The following is a description of a gene set: studied in species Homo sapiens Human Gene Set: WP_NANOPARTICLE_TRIGGERED_REGULATED_NECROSIS Nanoparticle triggered regulated necrosis, and this is the list of marker genes: FADD, PLA2G4A, TNFRSF1A (NCBI Gene Id 8077), FTL, TICAM1, PARP1, TNF, RIPK3 (NCBI Gene Id 11035), MAPK8, TRADD, RIPK1, CASP8